Given this list of marker genes CKS2, CDK5R1, MNAT1, CKS1B, CCND2, CCNT2, CCND3, CDK5R2, CCNK, CCNB1, CCND1, CCNT1, here is a description of the gene set: Binds to and increases the activity of a cyclin-dependent protein serine/threonine kinase. Human Gene Set: GOMF_CYCLIN_DEPENDENT_PROTEIN_SERINE_THREONINE_KINASE_ACTIVATOR_ACTIVITY studied in species Homo sapiens